Given this list of marker genes NEXN, ACTN3, ITGA3, CLDN5, CD99, AMIGO2 (adhesion molecule with Ig like domain 2), MAPK14, RASA1, ATP1A3, NRAP (NCBI Gene Id 4892), TRAF1, JAM3, GAMT, VCL, AMIGO1, CLDN9, HRAS, FYB1, FLNC, TNFRSF11B, CTNND1, GRB7, ADAM9, DSC1, CDH11, AKT2, MPZL1, PKD1, KCNH2, CDSN, CX3CL1, PIK3CB, CLDN4, PECAM1, CADM2, MVD, ARPC2, ACTC1, MPZL2, PLCG1, CDH6, INSIG1, LAMB3, NFASC (NCBI Gene Id 23114), CALB2, CDK8, EVL, MAP4K2 (NCBI Gene Id 5871), MSN, TMEM8B, MAPK11, MAP3K20, ALOX15B, DMP1, TRO, MYL12B, ACTN1, SPEG, ACTN4, PPP2R2C, EPB41L2, TUBG1, JUP, ICAM4, PARD6G, CDH15 (cadherin 15), ITGB4, ICAM2, PCDH1, ITGB1, SYK, MDK, VCAM1, SYMPK, CNN2, BMP1, NLGN2, PTK2, VASP, TSC1, GTF2F1, ZYX, CLDN19, ACTN2, CLDN11 (claudin 11), CLDN6, MMP9, CD276, CLDN7, SLIT2, IKBKG, THY1, SHC1, YWHAH, PTPRC, NLGN3, THBS3, PARVA, NECTIN4, GNAI2, CERCAM, INPPL1, SGCE (NCBI Gene Id 8910), CADM3, ACTA1, RRAS, LAMC2, MYH10, ITGA10, LAYN, KRT31 (keratin 31), COL16A1, ACTG2, CRAT, SHROOM2, LIMA1, RHOF, AMH, TIAL1, DSC3, CDH8 (cadherin 8), ACTG1 (NCBI Gene Id 71), NF2, ADRA1B, ARHGEF6, ITGA2, FBN1, BAIAP2, RAC2 (Rac family small GTPase 2), CDH3, PTEN, CDH1 (cadherin 1), NRXN2, LAMA3, STX4, NECTIN3, SDC3, VCAN, CD209, NEGR1, TSPAN4, NF1, COL17A1 (NCBI Gene Id 7828), ICAM5, HADH, CTNNA1 (catenin alpha 1), CDH4, VWF, SIRPA, NECTIN2, MADCAM1, MAPK13, CD274, CLDN14, TJP1, TAOK2, SORBS3, TGFBI, CD34, FSCN1, NHERF4 (NHERF family PDZ scaffold protein 4), CRB3, CLDN15, ACTB, AKT3, NRTN, DHX16, SRC, B4GALT1, DLG1, MYH9, MMP2, IRS1, COL9A1, PALS1, MYL9, NECTIN1, SLC30A3, EGFR, CNTN1, EXOC4, CLDN18, PFN1, PBX2, WNK4, ICAM1, CD86, SKAP2, ITGA9, VAV2, ADAMTS5, ADAM23, PIK3R3, CAP1 (cyclase associated actin cytoskeleton regulatory protein 1), RSU1, ADAM15, WASL, CLDN8, GNAI1, LDLRAP1 (NCBI Gene Id 81862), here is a description of the gene set: from publication Liberzon A, Birger C, Thorvaldsdóttir H, Ghandi M, Mesirov JP, Tamayo P (PMID 26771021) Human Gene Set: HALLMARK_APICAL_JUNCTION species: Homo sapiens Genes encoding components of apical junction complex.